Given this list of marker genes Slc4a3, Atp4b, Cckbr, Atp4a, Atp6v1b1 (NCBI Gene Id 269766), Rogdi, Tcirg1, here is a description of the gene set: studied in species Mus musculus Mouse Gene Set: GOBP_PH_REDUCTION Any process that reduces the internal pH of an organism, part of an organism or a cell, measured by the concentration of the hydrogen ion.